Given this list of marker genes Slc1a2, Ppfia3, Gls, Tspoap1, Syt1, Dnajc5, Cplx1, Rab3a, Slc18a3, Slc6a12, Snap25, Gad1, Slc1a6, Chat (choline O-acetyltransferase), Ppfia4, Ppfia1, Slc32a1, Lin7c, Slc6a13, Lin7a, Ppfia2, Maoa (monoamine oxidase A), Slc1a3, Stx1a, Stxbp1, Abat, Slc17a7, Apba1, Slc6a1, Slc22a1, Syn2, Gad2, Unc13b, Gls2, Slc22a2, Vamp2, Lin7b, Slc1a7, Slc1a1, Syn1, Slc6a11, Slc5a7, Rims1, Slc38a2, Slc18a2, Hspa8, Naaa, Arl6ip5, Cask, Syn3, Aldh5a1, here is a description of the gene set: Neurotransmitter release cycle Mouse Gene Set: REACTOME_NEUROTRANSMITTER_RELEASE_CYCLE species: Mus musculus